Given this list of marker genes SPPL3, HSPA8, ALG8, HLA-G, TAPBP, BCAP31, HLA-DQA2, SPPL2B, HLA-DRB4, PKD2, HLA-DRB3, BDH1, CTSA, NDUFAF5, HLA-DQB2, PAM16, HLA-DRB5, ALG3, HLA-E, COA8, HLA-DPA1, AQP2, SPPL2C, HLA-F, CALR, HLA-DPB1, HLA-H, AMBP, HLA-DQB1, ALG9, ALG10B, CANX, HLA-DRA, ALG12, DNAJC19, HLA-A, HLA-DQA1, NOA1, HLA-DRB1, KCNQ1, HM13, HLA-B, ALG6, CD74, HLA-C, SPPL2A, here is a description of the gene set: Any side (leaflet) of a membrane that faces the lumen of an organelle. Human Gene Set: GOCC_LUMENAL_SIDE_OF_MEMBRANE species: Homo sapiens